The following is a description of a gene set: The growth of a chondrocyte, where growth contributes to the progression of the chondrocyte over time. Mouse Gene Set: GOBP_CHONDROCYTE_HYPERTROPHY studied in species Mus musculus, and this is the list of marker genes: Mex3c, Tgfbr2, Smad7, Cst5, Rarg, Sox9, Ext1